Given this list of marker genes VPS11 (VPS11 core subunit of CORVET and HOPS complexes), VPS16, VPS33B, VPS18, VPS33A, VPS8, TGFBRAP1, here is a description of the gene set: studied in species Homo sapiens A multimeric protein complex that acts as an endosomal tethering complex (CORVET = class C core vacuole/endosome tethering) by cooperating with Rab GTPases to capture endosomal vesicles and trap them prior to the action of SNAREs; the complex is involved in endo-lysosomal biogenesis and required for transport between endosome and vacuole. The Saccharomyces cerevisiae complex contains Vps8p, Vps3p, Pep5p, Vps16p, Pep3p, and Vps33p. Human Gene Set: GOCC_CORVET_COMPLEX